The following is a description of a gene set: studied in species Homo sapiens An abnormality of myeloid leukocytes. Abnormal myeloid leukocyte morphology Human Gene Set: HP_ABNORMAL_MYELOID_LEUKOCYTE_MORPHOLOGY, and this is the list of marker genes: USP8, SLC7A7, TBK1, BCOR, POLD3, FTCD, UHRF1, TDP2, ERCC2, ASAH1, MTR, CBL, RAG1, PIK3CD, RPS17, CYBA, SLC27A4, SPPL2A, SLC37A4, TAFAZZIN, GLB1, RPS7, ZNFX1, APOE, NCF2, TFR2, BACH2, CDCA7, LAMTOR2, MPLKIP, MYD88, SLC30A7, PTPN6, AMN, PRTN3 (proteinase 3), RAB27A, MMACHC, MPL, FANCE, IKBKG, NPM1, TET2, SH2D1A, LYST, CD40LG, RMRP, RPS28, FDX2, PDGFRA, CYBC1, CD247, SFXN4, IFNG, SRP54, DDX41, NBAS, SGCG, SLC19A1, CD3D, CARD10, MYSM1, LRRC8A, ATRX, TLR8, BCL11B, STAT3, USB1, RPS19 (NCBI Gene Id 8378), SLC29A3, MVK, TBX21, BTK, JAGN1, FOXP3, KRAS, TPP2, RTEL1, DOCK8, ZAP70, CD79B, ABL1, NR3C1, VPS45, FBXW7, RPL9, HEATR3, GALE (NCBI Gene Id 2582), CD3E, RPL35A, TCF3, HTRA2, CYBB, DIAPH1, SMARCD2, NLRP3, TLR3, RPL18, NDUFA6, G6PC3, TSR2, ASXL1, FMO3, SH2B3, GTF2H5, CHD7, CDH23, FANCD2, TICAM1, SLC35C1, SLC39A7, SPINK5, CYP26C1, SMPD1, NPC1, VPS33A, UNC13D (unc-13 homolog D), BRAF, PMM2, NRAS, CAMK2B, SLC46A1, HELLS, DKC1 (dyskerin pseudouridine synthase 1), MMUT, HLA-DPA1, LIPA, MAD2L2, RPL26, CDC40, WDR1, LMBRD1, PTPN22, NCF4, FANCA, MST1, ERCC3 (ERCC excision repair 3, TFIIH core complex helicase subunit), ANAPC1, NLRP1, AGA, IFNGR1, FCGR3B, MMAA, SF3B1, TRAC, RPS15A, PML, ETV6, EPX, PRF1, GTF2E2, TBL1XR1, FIP1L1, EPG5, IKZF1, ZNF341, RNF113A, TONSL, PIK3CG, MYH9, BTNL2, TFRC, IRF2BP2, JAK2, ICOSLG, WAS, CUBN, SRP19, EFL1, SEC61A1, SEMA4D, RPS10, CXCR2, SPI1, GATA2, XIAP, TRAF3, IL36RN, SLC35A1, RPL31 (NCBI Gene Id 6160), DNAJC21, NPC2, NABP1, CD40, STXBP2, GINS1, CIITA, FIBP, FUT8 (NCBI Gene Id 2530), GPR35, CDSN, PNP, PRDX1, IGHM, ABHD5, RPL11, IL7R, RPS24, CALR, PIK3R1, ZBTB24, CBLB, MDM4, RPL8, STAT1, ZBTB16, GSS, NCAPG2, TCF4, TARS1, CARD9, TP53 (tumor protein p53), CD27, HAX1, FANCG, FASLG, FANCC, CXCR4, RECQL4, HSCB, ADA2, MSN, MTRR, STAT4, RPL35 (NCBI Gene Id 92393), RPS26, RPS20, WRAP53, CASP10, TERT, PRKAR1A, SCO2, FANCI (NCBI Gene Id 751608), CD79A, FAS, UNC93B1, IKBKB, JAK1, EXTL3, LBR, RPS29, DCLRE1C, STAT5B, CSF3R, RFXAP, SAMD9L, ARPC5, SRP68, GFI1, SBDS, FNIP1, OTULIN, HLA-B, LCP2, LIG4, MTHFD1, DOCK11, EIF2AK3, IL2RG, CARD11, AK2, GATA1, STAT6 (NCBI Gene Id 6778), PACS2, CLPB, HLA-DPB1, SRSF2, TYMS, WIPF1, CEBPE, FBXL4, RPL15, MEFV, ABCD4, RFX5, MMAB, SREBF1, HAVCR2, CTLA4, LRBA, ICOS, BLNK, KIT, RAG2, CAPN3, SAMD9, DNASE2, C1GALT1C1, NOP10, AP3D1, PSMB10, DNMT3B, ACP5, COG4, GPI, NSUN2, RFXANK, IGLL1, RPL27, IRF8, SMARCAL1, RPS27, TERC, MECOM, THPO, ITK, AP3B1, RBM8A, NEU1, ELANE, CTC1, RARA, CARS1, TCN2, MPO, SASH3, PPIL1, RPS14, RAC2, ADA, AARS1, RELB, RNU4ATAC, NHP2, PCCB, UBE2A, CRELD1 (cysteine rich with EGF like domains 1), TCIRG1, STK4, IRAK4, NUMA1, IL1RN, BCR, USP48, IPO8, HLA-DRB1, ITCH, RPL5, VPS13B, PCCA, PARN, PGM3, TMEM147, RUNX1, TINF2, IL6ST, NCF1, STX11